Given this list of marker genes Mgat2, Piga, Pomgnt2, Mgat5 (mannoside acetylglucosaminyltransferase 5), Alg13, Mfng, Mgat4b, Gcnt4, B3gnt4, Mgat4c, B4gat1, Extl1, Ext1, Hexb, Eogt, B3gnt5, Mgat4a, Pomgnt1, B3gnt7, Extl3, Gcnt7, Rfng, Mgat5b, Mgat3, Ogt, Gcnt3 (glucosaminyl (N-acetyl) transferase 3, mucin type), B3gnt8, B3gnt3, Pigq, B3glct, A4gnt, Mgat1, Hexa, Gcnt1, Lfng, Pigp, Ext2, Gcnt2, Pigyl, Mgat4d, Mgat4e, B3gnt2, Mgat4f, Extl2, B3gnt6, here is a description of the gene set: Catalysis of the transfer of an N-acetylglucosaminyl residue from UDP-N-acetyl-glucosamine to a sugar. Mouse Gene Set: GOMF_ACETYLGLUCOSAMINYLTRANSFERASE_ACTIVITY species: Mus musculus